Given this list of marker genes Rrbp1, Igkc, Rpn1, Pgam2, Spcs1, Tent5c, Slc44a1, Hdlbp, Tmem39a, Ubxn4, Hspa13, Sgpp2, Ccdc47, Derl1, Prrc1, Slc30a7, Scfd2 (NCBI Gene Id 212986), Ntaq1, Magt1, Bpgm, Dnajb9 (DnaJ heat shock protein family (Hsp40) member B9), Nans, Gpr89, Bet1, Cd28, Larp1b, Ssr2 (signal sequence receptor, beta), Htatip2, Tram2, Ddost, Tmem248, Qpctl, M6pr, Surf4, Bhlha15, Chrnb4, Spcs3, Creld2, Filip1, Armcx3, Nbas, Stt3a, Ebp, Manf, Mgat2, Tmed2, Ctsb, Ip6k1, Tesc, Igha, Gpr160, Ostc, Lman1, Sec11c, here is a description of the gene set: from publication Mori S, Rempel RE, Chang JT, Yao G, Lagoo AS, Potti A, Bild A, Nevins JR (PMID 18922927) Mouse Gene Set: MORI_PLASMA_CELL_UP The Emu-myc transgenic mouse has provided a valuable model for the study of B-cell lymphoma. Making use of gene expression analysis and, in particular, expression signatures of cell signaling pathway activation, we now show that several forms of B lymphoma can be identified in the Emu-myc mice associated with time of tumor onset. Furthermore, one form of Emu-myc tumor with pre-B character is shown to resemble human Burkitt lymphoma, whereas others exhibit more differentiated B-cell characteristics and show similarity with human diffuse large B-cell lymphoma in the pattern of gene expression, as well as oncogenic pathway activation. Importantly, we show that signatures of oncogenic pathway activity provide further dissection of the spectrum of diffuse large B-cell lymphoma, identifying a subset of patients who have very poor prognosis and could benefit from more aggressive or novel therapeutic strategies. Taken together, these studies provide insight into the complexity of the oncogenic process and a novel strategy for dissecting the heterogeneity of B lymphoma. studied in species Mus musculus Up-regulated genes in the B lymphocyte developmental signature, based on expression profiling of lymphomas from the Emu-myc transgenic mice: plasma cell.